The following is a description of a gene set: species: Mus musculus Mouse Gene Set: MIR_743B_3P Genes predicted to be targets of miRBase v22 microRNA mmu_miR_743b_3p in miRDB v6.0 with MirTarget v4 prediction scores > 80 (high confidence targets). from publication Chen Y, Wang X (PMID 31504780), and this is the list of marker genes: Zfp11, Rbms3, Trp53bp2, Hlf, Ddx18, Gabra1, Cd38, Bcor, Hectd2, Rpia, Mier1, Celf2, Rraga, Myef2, Il13ra1, Lancl3, Enpp4, Six1, Kctd14, Nkrf, Atad2b, Sema3a, Rasa2, Gdap1l1, Papolg, Junb, Frmd6, Lrrc63 (NCBI Gene Id 70859), Ube2c (ubiquitin-conjugating enzyme E2C), Top2a, Rgs13 (regulator of G-protein signaling 13), Ppp3cb, Adcy2, Cdyl2, Dennd6a, Cbx7, Ctsc, Ddx17, Ftsj1, Pik3r3, Phox2b, Zfp182, Ap5m1, Zfp871, Elavl2, Pcdh7, Tfap2a, Tiprl, Mrc2, Zc3h6, Suco, Pde3b, Errfi1, Slitrk5, Thap2, Crem, Pola1, Tbc1d8b, Jph1, Ebf1, Pde7a, Pogz, Zfp704, Nrep, Pip4p2, Trpc3, Mapre3, Ncbp3, Robo1, Slc38a10, Mapkapk2, Dipk2a, Bod1l, Pank3, Map2k1, Wdr26 (NCBI Gene Id 98607), Tfdp2, Nxph2, Etnk1, Cldnd1, Lrrc4c, Ppm1d, Rap2c (RAP2C, member of RAS oncogene family), Adra1a, Hoxb2, Onecut2, Dnajc12, Mprip, 4921524J17Rik, Larp1, Cilk1, Ces1f, Rora, Usp37, Dnajc10, Max, Zc3h12c, Hivep2, Pcdh9, Dcaf10, Snap25, Scin, Htr5a, Tnfsf9, Scara5, Adgrg1, Clta, Rrm2b, Nphs2, Tnpo3, Ikbip, Pcsk5, Sbno1, Mecp2, Tnfrsf9, Arhgef12, Iqsec2, Mbtd1, Semp2l2a, Zkscan8, Wdfy4, Stx12, Akap11, Rspo3, Gabra3, Mab21l1, Insr, Zbtb6, Synj1, Atad2, Dync1li2, Ube2e3, Ptpn9, Pcnp, Cadm1, Erbb4, Arid4a, Armh3, Hipk1, Tmem41b, Osbpl3, Sntb2, Klri2 (NCBI Gene Id 320407), Muc21, Msl2, Tnfaip3, Slc35d3, Glra2, Adam22, Bnc2, Edil3, Slc4a4, Mylip, Rab10 (RAB10, member RAS oncogene family), Npr3, Rwdd2b, Gdpd1, Dclk1, Cetn3, Nup98, Tpm1, Lgr4 (leucine-rich repeat-containing G protein-coupled receptor 4), Rad1, Psd3, Kat6b, Ano3, Ctsa, Arel1, Cop1, Elac1, Arhgap19, Syt4, Asxl2, Prrx2, Baiap2l1, Exosc1, Gpr174, Tchh, Crebrf, Cul2, Marcksl1, Tmem168, Sertad2, Bpnt2, Canx, Neto2, D16Ertd472e, Spag9, Gria4, Pou3f2, Nelfa, Arhgap20, Cd200l1, Sf1, Sirpb1c, Proser1, Dnaaf9, Ostm1, Vps50, Slc39a9, Minpp1, Ing2, Ahi1, Phf8, Wdr36, Arid2, Fsd1l, Ccdc85b, Brinp3, Aak1, Med30, Uhrf2, Ccdc88a (NCBI Gene Id 77927), Dr1, Nr1d2, Mrpl17, Lrig1, Wdr37, Ccn3, Pknox1, Enpep, Ythdf2, Wdr12, Cacnb4, Hook3, Rapgef6, Gnb5, Cep350, AI182371, Sytl4, Inpp5f, Pam, Reps2, Igsf1, Ppp4r3b, Lin28b, Esp18, Kif5b, Rce1, Mmp12, Zfp148, Prrg3, Cdk6, Mpp7, Smg1, Cwc22, Grk5, Mettl25b, Nr5a2, Rapgef2, Map3k1, B4galt6, Zfp709, Zfhx4 (NCBI Gene Id 80892), Efna5, Arl15, Pou2f1, Mosmo, Senp8, Dpy30, Dzip3, Atp11b, Mro, Dstyk (NCBI Gene Id 78855), Tbc1d2b, Fgf16, Mamdc2, Sirpb1b, Npas3, Ipmk, Dpy19l1 (NCBI Gene Id 68435), Fut9, Ggnbp2, Mxi1, T2, Krtap4-2, Map3k7, Snx10, Tenm4, Klhl15, Znfx1, Ago2, Cfdp1